Given this list of marker genes CSNK2A2, HSP90AA1, SPCS2 (NCBI Gene Id 9789), PPP1CA, XPO1, KPNB1, PPP1CC, PPP1CB, SEC11C, FURIN, SPCS3, SEC11A, CSNK2A1, SPCS1, HSP90AB1, HSPA8, CSNK2B, here is a description of the gene set: Respiratory syncytial virus (RSV) genome replication, transcription and translation Human Gene Set: REACTOME_RESPIRATORY_SYNCYTIAL_VIRUS_RSV_GENOME_REPLICATION_TRANSCRIPTION_AND_TRANSLATION species: Homo sapiens